Given this list of marker genes VGLL4, SNORD49B, MAPKAPK3, CYB5B (cytochrome b5 type B), RNY3, ATP11C, MPHOSPH8, HCN4, DSP, MAD1L1, DDB2, TMEM266, ALPK1, TNC, ZNF227, VWA8, C19orf81 (NCBI Gene Id 647744), ANK3, AASS, KBTBD6-DT, GHRLOS, UXS1, RN7SL446P, ARMC5, ELOVL6, MLKL, HERC5, RUNX1T1, RETREG1, PPP2R2A, SDSL, NRCAM, TTC41P, STON2, EFCAB14, ESM1, FBXL19-AS1, COMMD3-BMI1, HNRNPD-DT, HELB, TTC28-AS1, CEP76, ADAMTSL4-AS1, AP2B1, RPL39P40, UBQLN1-AS1, PSMA1, ARHGEF12, CORO1C, LINC02895, AFF3, MCOLN3 (NCBI Gene Id 55283), GTF2I, CRK, PRH1, SUB1, FLJ12825, PIWIL2, FRMD6, PAIP1, UQCC4, DPH2, MUL1, USPL1, G2E3 (NCBI Gene Id 55632), SEPHS1, ENO3 (enolase 3), MIR548AL, MCPH1-AS1, RNU6-841P, PFN1, HOTAIRM1, KSR1, SLC27A1, RNU6-1039P, GPCPD1, XPO6, LONP2, REXO2, LAMTOR5-AS1, FBXL19, ZNF74, EMC4, SPIN1, SYNPO2, SYCP2L (synaptonemal complex protein 2 like), SLC38A4-AS1, MECOM, ARHGAP24, ZNF302, PRICKLE1, TCF4, ROBO2, DNAJC7, WDR75, GPM6B, MED24, GCLM, TMBIM6, TLCD4, ITPK1, IPO11, CCND2, RORA-AS1, TLE2, TBCD, ENDOV, PRR4, LPP-AS2 (NCBI Gene Id 339929), SNORD49A, UBQLN1, HSP90B1 (heat shock protein 90 beta family member 1), KBTBD6, STAT1, SOCS2, USO1, AMPH, WWP2 (WW domain containing E3 ubiquitin protein ligase 2), CMTR2, LAMTOR5, PTCH1, HEATR5A-DT, ICE2, SOCS2-AS1, NRG4, BCL6, USP25, MIR4727, COMMD3, TBC1D7, CCDC85C, SLMAP (sarcolemma associated protein), CSF3R, ENPP2, ZNF19, SNHG29, LINC02939, ARID1B, FHL1, LGR5, FASTKD1, DSP-AS1, ELP3, LINC00431, NKX3-2, VGLL2, SIX2, CAPN8, NRL, AMN1, RCHY1, KCNQ2, CASP6, CTSS, SYPL1, NAA35, MDM4, NIPSNAP2, AFG3L2, PGM2L1, CISH (NCBI Gene Id 29917), RCN1, LDLR, BCAT1, GULP1, ADAR (NCBI Gene Id 3427), CWC25, GNE (glucosamine (UDP-N-acetyl)-2-epimerase/N-acetylmannosamine kinase), UBB, HNRNPD (heterogeneous nuclear ribonucleoprotein D), AQP4-AS1, TAS2R14 (taste 2 receptor member 14), here is a description of the gene set: studied in species Homo sapiens Human Gene Set: BCL6B_TARGET_GENES Genes containing one or more binding sites for (BCL6B) in their promoter regions (TSS -1000,+100 bp) as identified by GTRD version 20.06 ChIP-seq harmonization. from publication Yevshin I, Sharipov R, Kolmykov S, Kondrakhin Y, Kolpakov F (PMID 30445619)